Given this list of marker genes PI15, CFH, NUCB2, HEXIM1, RARRES2, COL14A1, PDGFRL, C1QTNF3, SFRP2, NPDC1, OSR1, MFAP5, CPE, RCN3, CRABP2, COL1A2, ELN, COL1A1, RNU6-2 (RNA, U6 small nuclear 2), IGFBP4, CTSK, C1R, OSR2, COLEC12, F10, TSHZ2, C1S, LOX, COL3A1, OLFML2B, S100A6 (NCBI Gene Id 6277), PPIC, ANGPTL1, SPARC, BGN, PI16, FBLN1, PCOLCE, ITM2A, EGFL6, ID2, S100A4, CCDC80, DUSP1, NTRK2, CPZ, SERPINF1, ACVR2A, here is a description of the gene set: Human Gene Set: CUI_DEVELOPING_HEART_SMOOTH_MUSCLE_CELL studied in species Homo sapiens from publication Cui Y, Zheng Y, Liu X, Yan L, Fan X, Yong J, Hu Y, Dong J, Li Q, Wu X, Gao S, Li J, Wen L, Qiao J, Tang F (PMID 30759401)